The following is a description of a gene set: Human Gene Set: HP_HYPOPLASTIC_FIFTH_FINGERNAIL A nail of the fifth finger that is diminished in length and width, i.e., underdeveloped nail of little finger. species: Homo sapiens Hypoplastic fifth fingernail, and this is the list of marker genes: PGAP2, DPF2 (double PHD fingers 2), PIGF, RBPJ, SMARCD1, ARID1B, SMARCC2, SMARCA4, SOX4, SMARCE1, SMARCB1, ARID1A, ARID2, SOX11